The following is a description of a gene set: studied in species Mus musculus The formation of scaffolds from a radial glial cell. The scaffolds are used as a substrate for the radial migration of cells. Mouse Gene Set: GOBP_FORMATION_OF_RADIAL_GLIAL_SCAFFOLDS, and this is the list of marker genes: Lef1, Flna, Arl13b, Itgb1, Lrp6